The following is a description of a gene set: Genes predicted to be targets of miRBase v22 microRNA hsa-miR-663a in miRDB v6.0 with MirTarget v4 prediction scores > 80 (high confidence targets). species: Homo sapiens Human Gene Set: MIR663A from publication Chen Y, Wang X (PMID 31504780), and this is the list of marker genes: AP5Z1, TGFB1, ESPN (NCBI Gene Id 83715), DUOXA2, SCRT1, STPG1, MDGA1, EEF1A2, TNFRSF8 (NCBI Gene Id 943), FKBP8, HOXC10, DPP9, NFIX, MIA2, ABO, ACSL3, SLC29A3